Given this list of marker genes ZNF275, PSG4, RASSF8, FAM117A, SUCLA2, SLC39A8, GRIN3A, SRRM4 (NCBI Gene Id 84530), TMT1B, NSMCE3, SF3A3, GCC1, NIPSNAP3A, HYCC1, PGPEP1, PLBD2, NT5DC3, HS6ST2, PAK1, ST6GALNAC5, MTCH2, CELF3, IKZF3, SHOX, MAN2A1, TPM1, NPY1R, FAM199X (NCBI Gene Id 139231), LURAP1L, SSR2, SEMA4G, VGLL3, ORAI2, PPP2R5C, PRR23C, ARHGAP9, PPME1, DYDC2, CCL28, SNAPC3, DUSP19, CDK15, CXCL9, LOX, STK17B, ZCCHC14, SNX20, FRMPD3, PLXNA2, PYGO1, CLIC5, GAGE1, SYT14, FAM117B, DDX6, TSHZ3, RPS6KA2, CORO1C, KCNB1, NAMPT, ADAM30, PALS2, MXRA5, MDGA2, ATG16L2, SYP, MAML1 (mastermind like transcriptional coactivator 1), KRT2, CA6, PELI1, IFT140, AAK1, APOBEC3F, NIPSNAP3B, EIF4E3, GPATCH2, RAB6D (RAB6D, member RAS oncogene family), MARCKSL1, MKKS, MYEOV, CREM, GNGT2, CDK8, CHP1, BAZ2A, MPPED2, COL4A2, CTNND1, GABBR1, MAP4K1, IMPG2, MEPCE, GIGYF1, ENTPD7, RAB6C, TRIM32, RLIM, HIP1, UBE3A, C1orf105 (NCBI Gene Id 92346), PPDPFL, KRT222, RBM19, FABP4, AKAP6, PSG1, ATP1B4, SLC1A2, SKIL, ELK1, SHISA7, DMP1, STX5, TSPYL4, SDC3, CCT4, DAB2, HNRNPL, JAZF1, ABCC4, EBAG9, METTL8, TIMM21, SYT6, STK4, GAGE12D, GASK1A (golgi associated kinase 1A), PRSS27, MAPK10, BCL9, PTPRC, IARS1, TSPAN12, SLC36A2, PATZ1, ARID4A, here is a description of the gene set: Human Gene Set: MIR6788_5P studied in species Homo sapiens Genes predicted to be targets of miRBase v22 microRNA hsa-miR-6788-5p in miRDB v6.0 with MirTarget v4 prediction scores > 80 (high confidence targets). from publication Chen Y, Wang X (PMID 31504780)